The following is a description of a gene set: Messenger RNA levels were measured in actively dividing fibroblasts isolated from young, middle-age, and old-age humans and humans with progeria, a rare genetic disorder characterized by accelerated aging. Genes whose expression is associated with age-related phenotypes and diseases were identified. The data also suggest that an underlying mechanism of the aging process involves increasing errors in the mitotic machinery of dividing cells in the postreproductive stage of life. We propose that this dysfunction leads to chromosomal pathologies that result in misregulation of genes involved in the aging process. studied in species Homo sapiens from publication Ly DH, Lockhart DJ, Lerner RA, Schultz PG (PMID 10741968) Human Gene Set: LY_AGING_OLD_UP Genes up-regulated in fibroblasts from old individuals, compared to those from young donors., and this is the list of marker genes: CRYAB, COMP, PTGS1, CST6, HTRA1, FMOD, MMP12 (NCBI Gene Id 4321)